Given this list of marker genes Fshb (NCBI Gene Id 14308), Arrb1 (NCBI Gene Id 74110), Grk2, Myh9, Arrb2, Adrm1, Fshr, here is a description of the gene set: species: Mus musculus A G protein-coupled receptor signaling pathway initiated by follicle-stimulating hormone binding to its receptor on the surface of a target cell, and ending with the regulation of a downstream cellular process. Mouse Gene Set: GOBP_FOLLICLE_STIMULATING_HORMONE_SIGNALING_PATHWAY